The following is a description of a gene set: studied in species Mus musculus Mouse Gene Set: GOBP_EXTRACELLULAR_MATRIX_ASSEMBLY The aggregation, arrangement and bonding together of the extracellular matrix., and this is the list of marker genes: Tnxb, Has2, Gas6, Pparg, Tgfb1, Pxdn, Clasp1, Sox9, Phldb1, Lamb1, Megf9, Thsd4, Smad4, Mad2l2, Mfap4, Tgfbr1 (NCBI Gene Id 674605), Col1a2, Eln, Has3, Has1 (NCBI Gene Id 15116), Plod3, Ntn4, Gpm6b, Tgfbr3, Phldb2, Rgcc, Lamb3 (NCBI Gene Id 16780), Antxr1, Atp7a, Emilin1, Fbln5, Dag1, Ramp2, Lox, Efemp2, Fkbp10, Notch1, Agt, Col6a1, Tie1, Ltbp4, Prickle1, Smpd3, Smad3, Clasp2, Col3a1, Myh11, Hapln2, Lamb2, Ihh, Qsox1